Given this list of marker genes Ppox, Alas1, Ireb2, Alas2, Alad, Urod, Uros, Hmbs, Cpox, here is a description of the gene set: Mouse Gene Set: GOBP_PROTOPORPHYRINOGEN_IX_BIOSYNTHETIC_PROCESS The chemical reactions and pathways resulting in the formation of protoporphyrinogen IX. studied in species Mus musculus